Given this list of marker genes EEF2, EDEM1, HSPB7, KLHL14, PRDM16, CABIN1, FGR, UBQLN1, XRN2, HSPA1A, BAG3, KLF8, PRKN, SLC2A14, HOXC9, SFMBT2, SLC2A3, EPS15, STRADB, HDAC6, PSEN1, RANGAP1, HOXD3, HSPA1B, TDP2, PRKCQ, RNF32, DVL2, ZBTB14, URB2, SQSTM1, UBD, POLD1, TRIM37, CARD14 (NCBI Gene Id 79092), here is a description of the gene set: Human Gene Set: GOCC_AGGRESOME studied in species Homo sapiens An inclusion body formed by dynein-dependent retrograde transport of an aggregated protein on microtubules.